The following is a description of a gene set: studied in species Homo sapiens Human Gene Set: MIR1291 Genes predicted to be targets of miRBase v22 microRNA hsa-miR-1291 in miRDB v6.0 with MirTarget v4 prediction scores > 80 (high confidence targets). from publication Chen Y, Wang X (PMID 31504780), and this is the list of marker genes: GPM6A, TIMM22, SHKBP1, XKR7, CYP2C18, NR3C1, DYNC1I1, RGS9BP, SRSF9, ARL4C, CUX1, FOXS1, ACAP3, EPHB2, MYORG, PIM1, LMOD1, VASH1, PTPRU (protein tyrosine phosphatase receptor type U), FHIP1B, SH3PXD2A, MBNL3, NF2, PGAP3, H2AX, ETV6, NUTM2G, PTPA, NOS1AP, MUC22, GLYCTK, ENTREP2, F5, VSIG4, SLC9A5, NPTXR, CES3, MFSD14B, OAZ2, TOR1AIP2 (torsin 1A interacting protein 2), ZHX1-C8orf76, LIMS2, AQP1, RALGDS, RASAL2, ODF2, MAGEA11, KIAA1549, SH2D5, FGFR3, CC2D1A, CEMIP2, KLHDC10, VWA5A, CABP7, PML, FOXP4, IQSEC3, ELOVL5, MGAT5, CYB561A3, TGM4, ESYT1, RNF123, SNRPB, CRTC1, NRIP1, LYNX1, ST6GALNAC6, KIAA0319L, CCDC97, IL1B, SLC6A3, IQCE (IQ motif containing E), EDC3, TIAM1, UNC13B (unc-13 homolog B), CDC42EP1, PGM5, IMPA2, RBFOX1, PHYHIP, ERMP1, FAAP100, USP37, USP45, PLPPR2, SCN1B, MAN1C1, ZMIZ1, HMOX1, PAK2, PAFAH2, KCNQ5, NFATC4, RASSF1, ARID3B, FBXO41, CDT1, PLA2G4C, REEP2, WNT11, DNAJB5, MECP2, FAM153A, KREMEN1, SHISAL1, CD79A, C11orf21, FBXO10, MAPKAP1, IQSEC2